Given this list of marker genes Blvra, Ip6k2, Nox4, Psen1, Nr2f2, Apoe (NCBI Gene Id 11816), Fgf1, Bmp2, Map3k13, Chordc1, Apc (NCBI Gene Id 11789), Map2k2, Men1, Magi3, Blm, Pde5a, Ccnd2, Ptpn22, Ralb, Adam17 (NCBI Gene Id 236174), Pih1d1, Pycard, Bccip, Trib2, Gstp2, Egfr, Ntf3, Ulk4, Lyn, Ceacam1, Lrp6, Axin1, Nek10, Pak1, Fgd2, Il34, Irgm1, Map2k1, Tnfrsf11a, Irak1, Taok3, Cd40, Lats1, Rps3, Plk1, Nf1, Rgs14, Nolc1, Agt, Irak3, Ptprc, Ptpn1, Igtp, Map3k4, Trib3, Wnt5a, Cripto, Cab39 (calcium binding protein 39), Epha4, Zeb2, Syk, Prkcd, Tenm1, Stk38, Gstp-ps, Cdkn2a, Cdkn1b, Pdgfa, Dtnbp1, Rgs2, Fzd5, Abl1, Sfrp2, Fgfr1, Cdk5rap3, Dusp7, Fzd4, Tsg101, Adam9, Ptprj, Gpr39, Fgd4, Adipoq, Map3k5, Cdk12, Cdk5rap1, Cd24a, Cd300a, Gstp3, Mapk8ip1, Pdgfb, Aida, Traf2, Tcim (NCBI Gene Id 69068), Edn1, Cdkn2c, Uchl1, Stil (NCBI Gene Id 230631), Tlr6, Ern2 (NCBI Gene Id 26918), Casp3, Cav3, Higd1a, Rapgef2, Heg1, Map3k12, Dusp1, Spry1 (sprouty RTK signaling antagonist 1), Trib1, Rgcc, Ccnd3, Ezh2, Kat2b, Fcer1a, Ntrk3, Slc8a1, Lrrk2, Map2k6, Hmga2, Pkib, P2rx7, Tead1, Inpp5k, Pdcd4, Edn3, Hexim2, Ccnd1, Pten, Psmd10, Syap1, Cblc, Ccny, Snca, Map2k7, Sash1, Pdcd10, Mapre3, Dnaja1, Fzd8, Inca1, Nppa, Ltf, Cemip (cell migration inducing protein, hyaluronan binding), Insr, Camk1, Tab1, Hgs, Ksr1, Tirap, Ern1, Hipk3, Sirt1, Ager, Spry4 (sprouty RTK signaling antagonist 4), Pparg, Fbxo7, Spdya, Pik3r5, Prkch, Sfn, Arhgef5, Kit, Psrc1, Sfrp5, Hmgcr, Nup62, Rasgrp1, Fem1a, Mapk8ip3, Gba1, Erbb2, Nrxn1, Gtpbp4, Spatc1l, Uvrag, Htr2b, Dusp10, Sfrp1, Gab1, Map3k10, Tpd52l1, Map2k4, Cav1, Prox1, Macroh2a1, Mst1, Hras, Erp29, Adrb2, Pkia, Robo1, D1Pas1, Etaa1 (Ewing tumor-associated antigen 1), Slc8a2, Rasip1, Spry2, Cdkn1a, Dvl2, Mst1r, Tfap4, Map3k11, Ajuba, Tnfsf11, Il1b, Myocd (myocardin), Irgm2, Vangl2, Src, Map3k1 (mitogen-activated protein kinase kinase kinase 1), Cdkn2d, Map3k7, Adra2a, Tnf, Pdgfrb, Spdye4a, Ccl19 (C-C motif chemokine ligand 19), Hhex (hematopoietically expressed homeobox), Lats2, Lime1, Fgf2, Pik3r6, Akt1, C1qtnf9, Pik3cg, Rhoa, Cib1, Ifng, Paqr3, Smpd1 (sphingomyelin phosphodiesterase 1, acid lysosomal), Htt (huntingtin), Thbs1, Gstp1, Pim1, Map4k2, Hyal2, Maged1, Dab2ip, Ddx3x, Dusp19, Gadd45a, Flt1, Ptpn6, Thy1, Traf6, Wee2, Cdkn2b, Ccr7, Tnfaip3, Kitl, Drd4, Tlr4, Slc8a3, Ppp2ca, Fgf18, Synpo2, Bcl10, here is a description of the gene set: Mouse Gene Set: GOBP_REGULATION_OF_PROTEIN_SERINE_THREONINE_KINASE_ACTIVITY Any process that modulates the rate, frequency, or extent of protein serine/threonine kinase activity. studied in species Mus musculus